Given this list of marker genes AP3D1, BLOC1S2, BLOC1S4, ACTR10, TMEM230, HDAC6, AP3B2, TMEM108 (transmembrane protein 108), MAP2, KIF3B, KIF5B, NETO1, AP3S1, BLOC1S1, MGARP, FEZ1, AP3M1, DCTN1, SPAST, KIF1C, SNAPIN, HSBP1, HIF1A, TERF2, MAP1A, ATG16L1, UCHL1, MAPK8IP3, AGTPBP1, HAP1, ATG5, RUFY3, DST, KIF21A, DLG2, BLOC1S3, AGBL4, HSPB1, FBXW11 (NCBI Gene Id 23291), SYBU, BLOC1S5, KIF4A, RUFY4, KIF1B, DTNBP1, SOD1, TRIM46, MAPT, NDEL1, ARMCX3, KIF5C, DYNC1H1, OPA1 (NCBI Gene Id 4976), TRAK1, AP3S2, KIF5A (kinesin family member 5A), ARL8A, PAFAH1B1, NEFL, AP3B1, RAB21, ARL8B, KIF3A, BORCS5, AP3M2, KIF1A, BLOC1S6, SPG7, RAB27B, here is a description of the gene set: Human Gene Set: GOBP_AXONAL_TRANSPORT studied in species Homo sapiens The directed movement of organelles or molecules along microtubules in axons.